The following is a description of a gene set: species: Mus musculus Mouse Gene Set: GOBP_POSITIVE_REGULATION_OF_COMPLEMENT_ACTIVATION Any process that activates or increases the frequency, rate or extent of complement activation., and this is the list of marker genes: Mbl2 (NCBI Gene Id 17195), Phb1, Trem2, C3, Il1b (interleukin 1 beta)